Given this list of marker genes Mtor, Ubtf, Nol11, Pwp1, Dedd, Polr1d, Gtf2h5, Polr2e, Polr1e, Macroh2a1, Taf1b, Polr1f, Nop53, Macroh2a2, Ddx11, Ncl, Ercc2, Pih1d1, Ercc3, Sirt7, Mars1, Ippk, Smarcb1, Tcof1, Ercc6, Smarca4, here is a description of the gene set: studied in species Mus musculus The synthesis of the large ribosomal RNA (rRNA) transcript which encodes several rRNAs, e.g. in mammals 28S, 18S and 5.8S, from a nuclear DNA template transcribed by RNA polymerase I. Mouse Gene Set: GOBP_NUCLEOLAR_LARGE_RRNA_TRANSCRIPTION_BY_RNA_POLYMERASE_I